Given this list of marker genes PTBP3, MAP3K7 (mitogen-activated protein kinase kinase kinase 7), SNAI2, LRRC42, RYR2, CDKN2AIP, MS4A13, SOCS6, ATP6V1G2, ANKDD1B, NR3C1, FAM174A, SEPTIN2, CIT (citron rho-interacting serine/threonine kinase), CCDC89, DGKH, PCDHB14, STXBP6, IL4R, RRM2B, MATCAP2, IRF8, ANKRD7, TBC1D2B, HASPIN, PIK3R1, TCAF2, FZD6, KIF1B (NCBI Gene Id 57598), VTI1A, CRK, SCYL2, BNC2, SPTBN1, ARHGAP18, GCLC, TOX, DUSP1, PTAFR, DSEL, DPH3, CEP97, GRIK3, CACNA1B, SNX29, MRPS28, NRP2, BICD2, ZBTB44, NRCAM, NCOA3, CAMK2D (calcium/calmodulin dependent protein kinase II delta), EFR3A, TPD52L3, SYT11, PSG1, CBX2, RIF1, COL19A1, RAVER1, CAMK2B, BRCA1, PURB, DDX3X, SAMD12, DOCK10, PIWIL4, ISL1, FBXO45, SLC35A5, ANK2, CASKIN1, SCAF4, CDK19, MGAT4A, OSBPL11, RC3H1 (NCBI Gene Id 149041), PEAK1, PDE10A, NDRG4, SCO1 (NCBI Gene Id 6341), DLEU7 (NCBI Gene Id 220107), PCDHB6, GPATCH8, ADAMTS16, TNRC6B, PTPRK, RSRC1, MKX, ETV1, ZFHX4, CTNNB1, FGFR1, RPF1, IPPK, CRISPLD2, COL4A1, PIP4K2C, THSD7A, FLRT2, MAF, SDHAF3, KCNC4, ZNF622, EIF4E, CYP26B1, LRP12, CALCRL, MIEF1, SETD3 (SET domain containing 3, actin N3(tau)-histidine methyltransferase), UBR3, MDM1, SMIM13, DCLK1, ZNF704, ANK3, KIDINS220, POLQ, LPGAT1, KIF21B, ANKIB1, TMEM154, TP53BP1, ZC3HAV1, FGF2, PCDHGA11, UBTD2, SUMO3, SLIT2, SHOX, ZNF621, PDE4D, MIDEAS, CPSF6, G3BP2, DNM3, BMPR2, ARIH1, AVL9, TNKS2, MEX3D, GABRG3, CERS6, SNTG1, RBPJ, TBC1D8, ILDR2, SNAP25, GPR6, SMAD1, FAM43A, USP9Y, COL6A5, ENTPD4, REEP1, C1orf74, RLN2, NUFIP2, HRK, TBC1D8B, ZNF280C, C1GALT1C1, ARID3B, CYSLTR1 (NCBI Gene Id 10800), GK5, WEE1, N4BP2, HMGCS1, LGI2, MFSD4B, UBE4B, PEX5L, SCAI, RAB11FIP2, ABCC5, TNFSF13B, STXBP5, SECISBP2L, KMT5B, CDK12, HNRNPR (NCBI Gene Id 10236), PCDH19, AGO4, FGD4, ARHGAP42, ZCCHC3, KLHL15, ARRB1, SEC14L1, CTTN, LRIT3, SLC45A4 (NCBI Gene Id 57210), FBXO30, ARGLU1, LYVE1, MYRFL, INO80D, PIAS2, RIC1, DPY19L1, NR1D2, PCDHB10, TBC1D19, DOK6, MYEF2, DBX2, NEDD4L, RNF38, KCTD4, INTS6, TCF7L2, STX6, RFX7, ATAD2B, GNAI3 (G protein subunit alpha i3), FOXN2, RDX, PLAG1, CLTCL1, PTMA, PCGF3, PPA1 (NCBI Gene Id 5464), TASOR2, VCPIP1, UBE2D1, TMPRSS11D, CDC42SE2, AMFR, ANKRD55, UNC5C, NUSAP1, JPH1, TMEM215, DIP2C, SOS2, CEBPZ, CHN2, SENP7, MRPL50, SNX2, PKP4, SHOC2, OTUD1, SLC41A2, JAZF1, ZC3H6, FOXD2, APOD, ALS2CL, CPEB3, TIPARP, ANKRD50 (ankyrin repeat domain containing 50), LRP1B, PZP, CCPG1, KCNV1, CBL, CHD7, GNB1, FAM110C, MAGEB16, ATP2B4, AUTS2, TRIP12, SRP54, PRKG2, NPAS3, PPM1B, PALLD, CREBRF (NCBI Gene Id 153222), CYRIA, PAPPA, TGIF2, BCCIP, MOSMO, CUL3, UBR5, DENND5A (NCBI Gene Id 23258), TFDP1, ADAM23, MAPK8, TGDS, EGR3, TESMIN, CAV1, POTEM, SLC25A12, LRRC51, SHCBP1, KIF13A, TDRKH, YWHAE, BCAT1, AKAIN1, CPPED1, RBL2, ABHD17B (abhydrolase domain containing 17B, depalmitoylase), DCUN1D5, KRIT1, KBTBD11, MYLK, PRKD3, ARL4A (ADP ribosylation factor like GTPase 4A), SEPTIN11, GCC2, MFAP5, FAM91A1, CNR2, USP31, CEACAM5, ADIPOR1, CSNK1G3, TLCD4, CNIH4, MOB1B, NUP133, PFN2, HECTD1, USP9X, USP37, PTGDR2, SPDYE5, UHMK1, GOSR1, CLDN23, RNASEL, OSBPL6 (NCBI Gene Id 84615), SLC16A1, CCDC77, CELF2, DR1, KCNA2 (NCBI Gene Id 3737), CXCL16, TBL1XR1 (NCBI Gene Id 81612), USP15, FBLN2, RTL5, COL3A1, SORBS2 (NCBI Gene Id 8470), CEP57L1, STK38L, DPY19L4, ARRDC3, LRP1, SRD5A1, ATG14 (autophagy related 14), SNIP1, PTCH1, APBB2, SCD5, PDZD8, MTX3, PAFAH1B2, LMO4, TRAF6, ATXN1L (ataxin 1 like), ZNRF3, LUC7L, RELN, LRIG1, RBBP6, ONECUT2, RMI1, CHUK, CADM1, RCOR1, DDX42, EIF4E3, TRIM33, CCDC25, TRIM66, METTL14 (NCBI Gene Id 57721), TUBGCP3, GRIA3, ARHGAP24, USO1, PSEN1, RASA1, MEX3B, SLC14A1, here is a description of the gene set: Human Gene Set: MIR545_3P studied in species Homo sapiens Genes predicted to be targets of miRBase v22 microRNA hsa-miR-545-3p in miRDB v6.0 with MirTarget v4 prediction scores > 80 (high confidence targets). from publication Chen Y, Wang X (PMID 31504780)